Given this list of marker genes Ada, Adal, Urad, Upb1, Ahcyl, Pnp2, Pycr3, Urah, Aicda, Nudt1, Dpyd, Xdh (xanthine dehydrogenase), Dera, Cdadc1, Cda, Upp1, Gda, Uox, Dctd, Ahcy, Upp2, Pnp, Enpp4, here is a description of the gene set: species: Mus musculus The chemical reactions and pathways resulting in the breakdown of any one of a family of organic molecules consisting of a purine or pyrimidine base covalently bonded to a sugar ribose (a ribonucleoside) or deoxyribose (a deoxyribonucleoside). Mouse Gene Set: GOBP_NUCLEOSIDE_CATABOLIC_PROCESS